Given this list of marker genes Upp2, Dpyd, Cdadc1, Aicda, Upp1, Tk1, Dctd, Dck, Cda, Pycr3, Tymp, Upb1, Dtymk, Tk2, here is a description of the gene set: Mouse Gene Set: GOBP_PYRIMIDINE_NUCLEOSIDE_METABOLIC_PROCESS The chemical reactions and pathways involving any pyrimidine nucleoside, one of a family of organic molecules consisting of a pyrimidine base covalently bonded to ribose (a ribonucleoside) or deoxyribose (a deoxyribonucleoside). studied in species Mus musculus